Given this list of marker genes BCL6, SLC35C1, DCAF12, CARD6, CLINT1, GTF2A1, ZCCHC10, ADAMTS6, CD200, GATAD2B, CDK19, S100A10, SH3BP5, POLD1, IL21R, C1GALT1, NSMCE1, SREBF2, P2RY10, BPTF, DNMT1, GNAI2, WASF2, PAN3, ISG15, FLI1, TRAPPC5, SELL, JAK2, SOCS7, SNX9, ENPP1, PIK3CG, RNF144A, VPREB3, SYNJ1, AFF4, DOCK11, MYH9 (NCBI Gene Id 65212), MTPN, RAB33B, TMEM64, CCDC97, KIF21B, SNX2, LMO2, ABCA1, FAM76B, ATP6V0A1, HDAC10, PDE4B, SNORD35B, MAPK11, FCHSD2, IFNAR1, CERK, TUBA1A, GNA13, TRIM25, IER2, SSH2, H3-3A, SLAMF1, FCMR, CALM2, PTBP3, LFNG, JAK1, TRIB2, PDE2A, MSN, RAB8A, SLAIN2, B3GNT8, AIDA, NDC80, SAMHD1, LAPTM5, DIPK1A, HSD11B1, DEXI, ZNF318, CNN2, VIM, TPM3 (tropomyosin 3), FLNB, ITSN2, GRAP2, SPRED2, ABCA6, PGAP1, SATB1, CHST3, GMFG, CDC25B, B3GNT5, FAM107B, RFC1, PLCL2, LSP1, ARHGEF3, RDH12, RIN3, RICTOR, ALCAM (activated leukocyte cell adhesion molecule), RIPOR2, MYLIP, ADD3 (adducin 3), ITGB7, KLF3, STAC2, CMAHP, TRIM59 (NCBI Gene Id 353185), ARHGEF18, CACNA1I, ICOSLG, PRIM1, SLC39A10, RHOH, RASGRP2, ADD1, NRM, ARHGAP25, LMBRD1, ATF7IP, EHD4, PARP1, KLF6, RASGRP3, CLEC2D, ATP1B1 (NCBI Gene Id 481), TEC, ROCK2, LBH, PICALM, ICE1, CC2D2B, AKT3, ARHGAP26 (NCBI Gene Id 23092), CYTIP, GPD2, CRIP3, ABCA7, CSNK1G3, CSK, TMSB10, KMT2E, RPS6KA3, FLNA, PPP3CA, PLEKHA2, XYLT1, GPR174 (NCBI Gene Id 84636), FRY, ANKRD44, IQGAP1, DNAJC9, DGKA, BACH2 (NCBI Gene Id 653980), SORL1 (NCBI Gene Id 6653), TRAK2, RASA3, BTLA, SSBP2, BRWD1, CHST15, FOXO1, IRF8 (interferon regulatory factor 8), CD55, TENT5A, MED13, IRF2, DGKD, RETREG1, DMXL1, AFF3, MYADM, STAP1, MEF2C, GRAMD1A, STAT4, here is a description of the gene set: from publication Kasturi SP, Skountzou I, Albrecht RA, Koutsonanos D, Hua T, Nakaya HI, Ravindran R, Stewart S, Alam M, Kwissa M, Villinger F, Murthy N, Steel J, Jacob J, Hogan RJ, García-Sastre A, Compans R, Pulendran B (PMID 21350488) Human Gene Set: GSE25677_MPL_VS_R848_STIM_BCELL_DN species: Homo sapiens Genes down-regulated in B lymphocytes after immunization with: monophosphoryl lipid A versus imiquimod. Many successful vaccines induce persistent antibody responses that can last a lifetime. The mechanisms by which they do so remain unclear, but emerging evidence suggests that activate dendritic cells (DCs) via Toll-like receptors (TLRs). For example, the yellow fever vaccine YF-17D, one of the most successful empiric vaccines ever developed, activates DCs via multiple TLRs to stimulate pro-inflammatory cytokines. Triggering specific combinations of TLRs in DCs can induce synergistic production of cytokines, which results in enhanced T cell responses, but its impact on antibody responses remain unknown. Learning the critical parameters of innate immunity that programs such antibody responses remains a major challenge in vaccinology. We demonstrated that immunization of mice with synthetic nanoparticles containing antigens plus Toll-like receptor (TLR) ligands 4 (MPL) + 7 (R837) induces synergistic increases in antigen-specific, neutralizing antibodies compared to immunization with a single TLR ligand. To determine whether there was any early programming of B cells, we isolated isotype switched, TCRbeta-CD11b-CD19+IgD-IgG+ B cells by FACS at 7 days post immunization with nanoparticles containing various adjuvants plus OVA, and performed microarray analyses to assess their molecular signatures.